Given this list of marker genes CCDC86, EFHD2, PRKRIP1, ZSCAN26, CD47, TANGO2 (transport and golgi organization 2 homolog), TNFSF8, OXCT1, DIO2, COMT, COA5, RBMS1, PCGF1, UBR4 (ubiquitin protein ligase E3 component n-recognin 4), GRN, SNTB2, KAT6A, CNOT3, SLC25A3, WIPF1, AP3M2, ARHGAP45, HSCB, MRTFA, TPK1, USB1, KCTD12, RERG, CSNK1G2, LAMC3 (laminin subunit gamma 3), HOXB3, GDA (guanine deaminase), TNFRSF9, ZFP36L2, RAB40C, ZNF524, PMEPA1, CCNQ, SPSB4 (splA/ryanodine receptor domain and SOCS box containing 4), TEX14, SMPDL3A (sphingomyelin phosphodiesterase acid like 3A), CORO2A, HEBP1, DPYS, KLRD1, DNTTIP1, MLLT1, MCL1, NAAA, RBMS2, ZDHHC7, SEC24B, FCGR3A, CDH9, TTC36, NUMB, MAZ, TAGLN, CCR2 (C-C motif chemokine receptor 2), DBNDD2, SCAND1, LNX1, EVI2A, ANKRD22 (ankyrin repeat domain 22), ANGPTL8 (angiopoietin like 8), PSIP1, IDNK, OSBPL9, COMMD7, MYL6B, SMOX, ZBTB16, ZFAND2A, ATP11B, CHPT1, UCP2, UBE2H, TCF7L2, EHD4, GAS1, LTBP1, BHLHE22, SPZ1, AKT3, ITPRID2, CXCR4, MROH1, PTGFR, BATF3, ARGLU1, SMC5, XRCC1, NSG2, GNPDA1, RPL13A, CLASRP (CLK4 associating serine/arginine rich protein), ACOT1, INTS12, SPOP, GCA, KDM5B (NCBI Gene Id 10765), RELA (RELA proto-oncogene, NF-kB subunit), CARS1, TCTE1, MATK, THY1, GAD2, SPAG5, ARHGAP5, SPDL1, CHKA, TSC22D1, REEP3, NXF1, CFI, SRRD, MCM10, SNX20, PLEKHO2, SFXN2, GK2, RTF2, CDKN1B, RNF38, ACAA2, FRYL, TNRC6A, TMUB2, ANKS3, SRP68, RSPH9, HOXA7, DSCAM, ST6GALNAC4, DRD4, GFRA3, PLEKHA2, WAC, INPP5K, KLF6, SCN3A, SDC1, S100A8, GTF2F1, TREM2, PTCD1, PTS, HCFC1R1, RBCK1, NEU1, TMOD4, UBL5, SLC25A20, EHD2, PRRG2, TXNDC16, CTDSP2, KDM6A, CHRD, HAAO, TIMP2, LIPA, ZMIZ2, DDX4, ISY1, CCDC97, ZC3H7A, HLX, CCNT2, CD27, SLC44A2, RGL1, CEP89, IDS, EPC1 (NCBI Gene Id 80314), PIM1, EVA1A, B3GNTL1, CCNA1 (NCBI Gene Id 8900), AP1G2, KIN, DPEP3, L1CAM, TTC14, EFNB2, PFKFB3, SON, PPP4R3B, LGALS3BP, EZH1, IKZF2, ZNF329, POMP, CLN8, C11orf91, FAAH, POU3F2, MTCP1, IGBP1, AHCYL1, here is a description of the gene set: Genes up-regulated in comparison of dendritic cells (DC) stimulated with poly(I:C) (TLR3 agonist) at 24 h versus DC cells stimulated with Gardiquimod (TLR7 agonist) at 24 h. mouse primary BMDCs were stimulated with tlr ligands and gene expression changes were profiled on Affymetrix arrays from publication Amit I, Garber M, Chevrier N, Leite AP, Donner Y, Eisenhaure T, Guttman M, Grenier JK, Li W, Zuk O, Schubert LA, Birditt B, Shay T, Goren A, Zhang X, Smith Z, Deering R, McDonald RC, Cabili M, Bernstein BE, Rinn JL, Meissner A, Root DE, Hacohen N, Regev A (PMID 19729616) species: Homo sapiens Human Gene Set: GSE17721_POLYIC_VS_GARDIQUIMOD_24H_BMDC_UP